The following is a description of a gene set: Wnt signaling modulation, Wnt inhibitor. Pathway ID: N01442. Pathway type: Reference. Pathway class: nt06505 WNT signaling. species: Homo sapiens Pathway Definition from KEGG: (SFRP,WIF1,CER1,NOTUM,TRABD2) -| WNT Human Gene Set: KEGG_MEDICUS_REFERENCE_WNT_SIGNALING_MODULATION_WNT_INHIBITOR, and this is the list of marker genes: TRABD2B, WNT10B, WNT6, WNT1, WNT5A, NOTUM, WNT5B, WNT2B, WNT16, TRABD2A, WNT10A, SFRP4, FRZB (NCBI Gene Id 2487), CER1, WNT9B, WNT7B, WNT3A (NCBI Gene Id 89780), WNT8A, SFRP1, SFRP5, WNT7A, WNT4, WNT9A, SFRP2, WNT2, WIF1, WNT8B, WNT3